The following is a description of a gene set: Mouse Gene Set: GOBP_NEGATIVE_REGULATION_OF_FIBROBLAST_MIGRATION species: Mus musculus Any process that decreases the rate, frequency or extent of fibroblast cell migration. Fibroblast cell migration is accomplished by extension and retraction of a pseudopodium., and this is the list of marker genes: Arhgap4, Fgf2, Has1, Zeb2, Braf, Nherf1, Rac1, Macir, Hyal2, Itgb1bp1 (NCBI Gene Id 16413), Cygb, Adipor2